The following is a description of a gene set: Human Gene Set: MIR6790_5P studied in species Homo sapiens from publication Chen Y, Wang X (PMID 31504780) Genes predicted to be targets of miRBase v22 microRNA hsa-miR-6790-5p in miRDB v6.0 with MirTarget v4 prediction scores > 80 (high confidence targets)., and this is the list of marker genes: PLXNA4, SLC2A2, OLA1, LRPPRC, APELA, ERICH3, GDAP2, CPM, APOBEC3D, RIMKLA, TCF20, KLHL11, FOXI2, SERPINA5, NLGN4Y, PTHLH, COL15A1, ARID5B, WLS, CALCOCO1, RASSF9, LYPLAL1, PHF20L1, NRN1, IDH1, KBTBD6, PRELID1, PRKCQ, STK39 (serine/threonine kinase 39), UBA3, SOAT1, TASOR2, GDF6, GOLGA1, ZCCHC2, RSRP1, PDE1A (phosphodiesterase 1A), KALRN, CNMD, CDC14A, HADH, NSD1, SLC35F4, MALT1, ZNF772, EHHADH, INS-IGF2 (INS-IGF2 readthrough), ARPP21, LONRF1